Given this list of marker genes WDR73, ARHGDIA, NUP37, ACTN4, TBC1D8B (NCBI Gene Id 54885), PAX2, NUP160, MAGI2, NPHS1, WT1, PTPRO, OSGEP, LAMB2, COQ6, TRPC6, TP53RK, PLCE1, NUP205, ANKFY1, INF2, YRDC, CRB2, NUP133, ADA (NCBI Gene Id 100), NPHS2, COL4A3, AVIL, GAPVD1, DAAM2, SGPL1, ARHGAP24, NUP107, COQ8B, APOL1, MYO1E, GON7, EMP2, CD2AP, ANLN, NUP85, NUP93, here is a description of the gene set: species: Homo sapiens Diffuse mesangial sclerosis Thickening and scarring (sclerosis) of the mesangium (a structure in the glomerulus). The sclerosis affects a large portion of the mesangium across multiple glomeruli. Histologic features include an increase in the mesangial matrix, thickened glomerular basement membrane, tubular casts, and interstitial inflammation. Diffuse mesangial sclerosis presents with nephrotic syndrome at birth or within the first year of life. Glomeruli are small and condensed in appearance, with early lesions showing increased loose mesangial collagen that progress to sclerosis with dense collagen without hypercellularity. Podocytes do not show hyperplasia but may be immature and cobblestone-like. Electron microscopy shows extensive foot process effacement without deposits, but increased collagen within mesangial areas. Human Gene Set: HP_DIFFUSE_MESANGIAL_SCLEROSIS